Given this list of marker genes Shoc1, Syce3, Trip13, Rec8, Bend2, 1700028K03Rik, Ehmt2, Spata22, Meioc, Aspm, Cep63, Cenpe, Sycp1, Mnd1, Terf1, Ttk, Mei4, Washc5, Ccnb2, Fbxo5 (F-box protein 5), Mcmdc2 (NCBI Gene Id 240697), Cenpc1, Rnf212, Mos, Ago4, Mlh1, Ccne1, Haspin, Tex12, Actr3, Golga2, Ska1, BC005624, Zcwpw1, Sgo1, Ccne2, Kash5, Brca2, Smc2, Ncapd3, Morc2b, Top2a, Prdm9 (PR domain containing 9), Cpeb1, Syce2, Ncaph, Ska3, Spo11, Ppp2r1a, Sycp3, Msh4, M1ap, Iho1, Plk1, Ddb1, Tex11, Sun1, 4930447C04Rik, Mei1, Chfr, Meikin, Ncaph2, Dcaf13, Fancd2, Atm, Tex15, Mapk15, Ankrd31, Dmc1 (NCBI Gene Id 13404), Zwint, Msh5, Mlh3, Terb2, Stag3, Knl1, Ccnb1ip1, Washc1, Actr2, Aurka, Pttg1, Terb1, Brip1, Psmc3ip, Mre11a, Ube2b, Bag6 (NCBI Gene Id 80605), Spdya, Syce1, Ndc80, Ndc1, Septin1, Espl1, Fmn2, Ska2 (spindle and kinetochore associated complex subunit 2), Rnf212b, Meiob, Smc4 (NCBI Gene Id 97076), Tex19.1, Nuf2 (NCBI Gene Id 98608), Pten, Hormad1, Syce1l, Rad21l, Syde1, Sirt7, Mael, Majin, here is a description of the gene set: studied in species Mus musculus Mouse Gene Set: GOBP_MEIOTIC_CHROMOSOME_SEGREGATION The process in which genetic material, in the form of chromosomes, is organized into specific structures and then physically separated and apportioned to two or more sets during M phase of the meiotic cell cycle.